Given this list of marker genes Pecr, Unc80, Xrcc5, C530043A13Rik (NCBI Gene Id 319357), Vil1, Ikzf2, Atic, Rpl31-ps14, Gm29183, Gm8885, Gm25411, Lancl1, Stk36, Gm8840, Apol7d, Ankar, Gm39662 (predicted gene, 39662), Pinc, Ctdsp1, Igfbp5, Fn1, Gm4319, D530049I02Rik, Mreg, Gm8805, Gm5256, Slc11a1, Gm8809, Gm6947, Kansl1l, Gm15843, Crygf, Spag16, Gm27934, Bard1, Bcs1l, Mir26b, Cxcr2, Cnot9, Gm8870, Usp37, Gm28497, Acadl, Tmem169, Gm29185, Catip, Gm15826, Tnp1, 4930556G22Rik, Gm28926, Rpl37a, Gm23422, Gm8883, Gm15669, Map2, Smarcal1, Mir1928, Abca12, Rpe, Gm28923 (NCBI Gene Id 102640346), Gm19335, Cps1, Pced1c-ps, Gm25832, Gm23879, Gm5255, Igfbp2, 6820402A03Rik, Aamp, Gm15793, Gm25939, Gm9553, Marchf4, 4933417E11Rik, Tmbim1, Gm25542 (predicted gene, 25542), Gpbar1, Gm18035, Cxcr1, Gm28818, Myl1, Kif22-ps, Vwc2l, Teshl, Gm5829, Arpc2, Gm15789, Gm10558, Erbb4, Rufy4, Gm8812, Tns1, Gm5528, Mir6351, Plcd4, Rnf25, Gm26342, Gm24729, Zfp142, Gm28364 (NCBI Gene Id 108167628), Pnkd, here is a description of the gene set: species: Mus musculus Mouse Gene Set: chr1C3